Given this list of marker genes MAP3K7, FLNA, SALL4, TBX5, LMX1B, RBM8A, here is a description of the gene set: Human Gene Set: HP_APLASIA_HYPOPLASIA_INVOLVING_THE_MUSCULATURE_OF_THE_UPPER_LIMBS species: Homo sapiens Absence or underdevelopment of the musculature of the upper limbs. Aplasia/Hypoplasia involving the musculature of the upper limbs